The following is a description of a gene set: Receptor-type tyrosine-protein phosphatases studied in species Homo sapiens Human Gene Set: REACTOME_RECEPTOR_TYPE_TYROSINE_PROTEIN_PHOSPHATASES, and this is the list of marker genes: PPFIA4, SLITRK1, SLITRK6, SLITRK5, SLITRK3, PTPRF, PTPRS, PTPRD, PPFIBP2, IL1RAP, SLITRK4, PPFIBP1, PPFIA1 (PTPRF interacting protein alpha 1), LRRC4B, IL1RAPL1, IL1RAPL2, PPFIA2, SLITRK2, PPFIA3, NTRK3